The following is a description of a gene set: Any process that modulates the rate, frequency or extent of the establishment of planar polarity, the coordinated organization of groups of cells in a tissue, such that they all orient to similar coordinates. Mouse Gene Set: GOBP_REGULATION_OF_ESTABLISHMENT_OF_PLANAR_POLARITY studied in species Mus musculus, and this is the list of marker genes: Pkhd1, Sfrp2, Sfrp5, Vangl2, Sapcd2, Sec24b, Spag6l, Sfrp1, Jhy